The following is a description of a gene set: species: Mus musculus Mouse Gene Set: GOBP_SARCOMERE_ORGANIZATION The myofibril assembly process that results in the organization of muscle actomyosin into sarcomeres. The sarcomere is the repeating unit of a myofibril in a muscle cell, composed of an array of overlapping thick and thin filaments between two adjacent Z discs., and this is the list of marker genes: Casq1, Myh6, Actn2, Cfl2, Tnnt2, Myom3, Prkar1a, Myom2, Flnc, Cav3, Flii (flightless I actin binding protein), Itgb1, Neb, Six4, Actg1, Myoz1, Csrp2, Krt8, Mybpc2, Mef2c, Tpm1, Mylk3, Akap13, Tnnt3, Hdac2, Ankrd23, Srf, Edn1, Fhod3, Krt19, Neurl2, Plec, Myoz2, Mybpc1, Ep300, Myom1, Mypn, Lmod2, Csrp1, Tnnt1, Bmp10, Mybph, Xirp1, Prkd1, Ttn, Mfn2, Ldb3, Synpo2l, Capn3, Casq2, Wdr1, Mybpc3, Tcap, Csrp3, Prox1